Given this list of marker genes BZW1, SH2D4B, NQO1, DCAF11, SS18 (NCBI Gene Id 6760), PRRC1, COX15, MACIR, CCDC82, TMEM72, TMX4, CREG2, KIAA0408, LRRC15, CDK14, DNM3, SLF1, SOX2, CRACDL, ZNF677, SLITRK3, ZNF365, CEP350, TEF, MS4A3, CLASP1 (NCBI Gene Id 23332), CERS2, IFNA17, ENHO, CSPG5, SMG7, CAAP1, NR4A3, TESPA1, LRAT, TBL1XR1, HMCN1, RSF1, HTRA4, SPRY2, EIF5AL1, FRS2, EPHA10, ABHD13, RUNX2, ANTXR1, SMURF1, BNC2, POC1B, TMEM132D (transmembrane protein 132D), RNF169, SOCS7 (NCBI Gene Id 30837), SEC24A, RARB, RAB6A, PATE4, DEK, CYRIB, NSUN7, CFL2, KIAA0753, COL11A1, MTCL3, ZNF431, LRRFIP2, RAPGEF2, WASHC5 (NCBI Gene Id 9897), CKAP5, KCNB2, PTCHD4, SMG1, RAD51D, COL13A1, FSD1L, TAF8 (NCBI Gene Id 135763), ZBTB2, DUSP12, DBN1, ZNF714, ZNF384, RAD23B, CLCN4, TSC22D2, MARCHF7, RBMXL1, WIPI1, FEM1B, PDS5B, GPNMB, CEP97, LMLN, IFNA10, SEMA3A, ZNF575, STT3B, LBH, RAB6C, SAMD12, SLC35E4, here is a description of the gene set: Genes predicted to be targets of miRBase v22 microRNA hsa-miR-4659b-5p in miRDB v6.0 with MirTarget v4 prediction scores > 80 (high confidence targets). from publication Chen Y, Wang X (PMID 31504780) studied in species Homo sapiens Human Gene Set: MIR4659B_5P